The following is a description of a gene set: Mouse Gene Set: GOBP_NEGATIVE_REGULATION_OF_GLIAL_CELL_APOPTOTIC_PROCESS Any process that stops, prevents, or reduces the frequency, rate, or extent of glial cell apoptotic process. species: Mus musculus, and this is the list of marker genes: Prkca, Prkci (protein kinase C, iota), Prkch, Prkcd, Trem2, Dll1, Rad21, Traf2, Igf1, Gas6, Ccl12 (NCBI Gene Id 20293)